The following is a description of a gene set: studied in species Mus musculus Gap junction degradation Mouse Gene Set: REACTOME_GAP_JUNCTION_DEGRADATION, and this is the list of marker genes: Clta, Ap2m1, Actb, Cltc, Gja1, Cltb, Actg1, Dnm1, Dnm2, Dab2, Myo6